Given this list of marker genes CYP7A1, CYP39A1, CYP46A1, SCARB1, APOE, AKR1D1 (NCBI Gene Id 6718), SNX17, SCARF1, CYP27A1, here is a description of the gene set: species: Homo sapiens The chemical reactions and pathways resulting in the breakdown of cholesterol, cholest-5-en-3 beta-ol, the principal sterol of vertebrates and the precursor of many steroids, including bile acids and steroid hormones. Human Gene Set: GOBP_CHOLESTEROL_CATABOLIC_PROCESS